Given this list of marker genes Tmod4, Tmem39a, Lmod2, Clec16a, Shroom2, Twf1 (twinfilin actin binding protein 1), Atxn7, Eps8, Add1, Capza2, Bmerb1, Apc2, Mid1ip1, Map1a, Capg, Hdac6, Lima1, Clasp2, Vil1, Scin, Tpm1, Sptan1, Camsap3, Carmil1, Capza3, Capza1, Lmod1, Bbof1, Ccdc88c, Swap70, Gsn, Tmod3, Trim54, Evl, Dbnl, Katnb1, Tnf, Gas2l1, Apc, Capzb, Nav3, Irak3, Plekhh2, Sptb, Per2, Carmil2, Stmn2, Scaf4, Map1b, Capza1b, Clasp1, Gas2l2, Arpc2, Scaf8 (SR-related CTD-associated factor 8), Mtpn, Ubqln4, Flii, Myh9 (NCBI Gene Id 97972), Wdr47 (WD repeat domain 47), Taok1, Tmod1, Eml4, Tmod2, Avil, Ttbk2, Dmtn, Rubcn, Cracd, Diaph3, Spta1, Add3, Mid1, Map2, Camsap1, Ckap2, Lmod3, Spef1, Twf2, Svil, Add2, Map6d1, Cib1, Rp1, Arhgef2, Specc1l, Sptbn1, Cfl1, Hdgfl3, Fgf13, Rdx, Pik3ca, Camsap2, Vill, Phf23, Tpx2, here is a description of the gene set: Any process that stops, prevents, or reduces the frequency, rate or extent of protein complex disassembly, the disaggregation of a protein complex into its constituent components. Mouse Gene Set: GOBP_NEGATIVE_REGULATION_OF_PROTEIN_CONTAINING_COMPLEX_DISASSEMBLY species: Mus musculus